The following is a description of a gene set: part of: SMAC, XIAP-regulated apoptotic response electronically inferred by orthology from the curated human pathway This event has been computationally inferred from an event that has been demonstrated in another species.<p>The inference is based on the homology mapping from PANTHER. Briefly, reactions for which all involved PhysicalEntities (in input, output and catalyst) have a mapped orthologue/paralogue (for complexes at least 75% of components must have a mapping) are inferred to the other species. studied in species Mus musculus Reactome Pathway: SMAC(DIABLO)-mediated dissociation of IAP:caspase complexes, and this is the list of marker genes: Casp7